The following is a description of a gene set: species: Homo sapiens Human Gene Set: HP_DIASTASIS_RECTI Diastasis recti A separation of the rectus abdominis muscle into right and left halves (which are normally joined at the midline at the linea alba)., and this is the list of marker genes: CHST14, RTL1, PORCN, IGF2, CDKN1C, CHAMP1, GPC3, MTOR, SOX6, DLK1, FOXF1, PPP2R3C, MEG3, KCNQ1OT1, SHPK, COLEC11, ELMO2, COLEC10 (collectin subfamily member 10), MASP1, TBCK, GUSB, KCNQ1, H19, EZH2, GPC4, GNPTAB, B3GLCT, PIGQ